The following is a description of a gene set: Phosphatase and tensin homologue deleted from chromosome 10 (Pten) is expressed aberrantly in non-small cell lung cancer cells, but the role of Pten in lung neoplasia has not been fully elucidated. In this study, we used a genetic approach to inactivate Pten in the bronchial epithelium of mice. Although, by itself, Pten inactivation had no discernible effect on bronchial epithelial histology, it accelerated lung tumorigenesis initiated by oncogenic K-ras, causing more rapid lethality than that induced by oncogenic K-ras alone (8 weeks versus 24 weeks of median duration of survival, respectively). Lung tumors arose in K-ras mutant, Pten-deficient mice that rapidly obstructed bronchial lumina and replaced alveolar spaces. Relative to K-ras mutant tumors, the K-ras mutant, Pten-deficient tumors exhibited more advanced histologic severity and more prominent inflammation and vascularity. Thus, Pten inactivation cooperated with oncogenic K-ras in promoting lung tumorigenesis. species: Mus musculus Human Gene Set: IWANAGA_CARCINOGENESIS_BY_KRAS_DN Cluster 4: genes down-regulated in lung tissue samples from mice with tumor-bearing genotypes (activated KRAS alone or together with inactivated PTEN). from publication Iwanaga K, Yang Y, Raso MG, Ma L, Hanna AE, Thilaganathan N, Moghaddam S, Evans CM, Li H, Cai WW, Sato M, Minna JD, Wu H, Creighton CJ, Demayo FJ, Wistuba II, Kurie JM (PMID 18281487), and this is the list of marker genes: CEP70, PCDHB12, TBCE, SAFB2, MYOZ2, ITGA6, PARP1, KRTAP5-5, MAB21L1, PDSS1, RPGRIP1, VPS36, C15orf48, HTR2B, CADM2, CALB1, GTPBP1, MOGS, MYCT1, RPL22, ABCA6, IRS2 (NCBI Gene Id 90066), AKTIP, ZSCAN22, ITPRIPL2, UPK3BL1, TMEM200A, KLF4, PIGN, PPP2R5C, PPP1R11, ZSCAN5B, COX7B2, SRSF1, ENO3, FIBIN, ETFDH, SP1, KLF7, ITGB4, CYP4B1, SULT1A1, BMAL2, ALOX12, PITPNB, SPAG16, SH2B1, BMPR2, CFD, RGS2, RCBTB2, CYP2E1, H1-2, LIMK1, H1-7, MALAT1, TERF2IP, PLXNB1, KRCC1 (lysine rich coiled-coil 1), PLEKHM2, HSPA12B, AP2A1, MYH6, RFNG, ABCB1, SLC43A2, LRP6, INTS12, SKAP2, DLL1, TCF4, KLRB1, GTF3C5, SNRPG, GRIK4, ZNF780A, ZNF23, FEZF1, DBP, ITGA2B, ARHGAP5, MADD, IRGM, LHFPL2 (NCBI Gene Id 285713), NR2F2, REXO1, ART2BP, TBC1D8B, TRIM14, SCML4, GNAQ, TSPAN11, TMEM243, HDAC6, NEURL1B, ZSCAN12, TRIO, FLT1, FGF12, TNNC1, DDX3Y, HNRNPR, NPM1, LETM1, NUDCD3, PRKCE, CAPNS2 (NCBI Gene Id 92942), CTDSP2, SPON1, NSMCE2 (NCBI Gene Id 286053), ITGA1, MAP3K14, FCRL1, GRIA2, FLNA (filamin A), PTEN, GALR1, FREY1, KIAA0040, PIK3IP1, ITGB5, SP3, GBP2